The following is a description of a gene set: Human Gene Set: GOCC_EPSILON_DNA_POLYMERASE_COMPLEX A heterotetrameric DNA polymerase complex that catalyzes processive DNA synthesis in the absence of PCNA, but is further stimulated in the presence of PCNA. The complex contains a large catalytic subunit and three small subunits, and is best characterized in Saccharomyces, in which the subunits are named Pol2p, Dpb2p, Dpb3p, and Dpb4p. Some evidence suggests that DNA polymerase epsilon is the leading strand polymerase; it is also involved in nucleotide-excision repair and mismatch repair. species: Homo sapiens, and this is the list of marker genes: POLE (NCBI Gene Id 80252), CHRAC1, POLE2, POLE4, POLE3